The following is a description of a gene set: species: Homo sapiens Genes predicted to be targets of miRBase v22 microRNA hsa-miR-6882-5p in miRDB v6.0 with MirTarget v4 prediction scores > 80 (high confidence targets). from publication Chen Y, Wang X (PMID 31504780) Human Gene Set: MIR6882_5P, and this is the list of marker genes: RPS16, XRN1, LRRC17, NFIA, MAP7D2, HOOK3, TFDP1, ZNF451, GIMAP1, NUFIP2, GTF2A1, USP6NL, RASA2, CNOT6, CHIC1, ZNF594, ERI2, TM9SF2, CCDC32, STXBP5, UBE2E2, PLXNA1, PARD3, CASTOR1, DCAF12, ASB8, ANKIB1, CFAP97, MYO1B, PTP4A1, CXCL5, ILDR1, DCX, PARD6B, HGF, SKIL, MITF, SOCS5, GMNC, SPOPL, WEE1, AKIRIN1, LIPI, KIF13B, RCSD1, MYLIP, MINDY2, TENT2, CPEB3, TIMM23B, MEIS2, HYCC2, KDM5A, ARIH1, GOLGA1, SLMAP, MARF1, XPO1, SOWAHC, ZMYM1, SUDS3, AQP1, CCL13, IGSF10, CEMIP2, DIP2B, CAB39, SIPA1L1, COX7A2, NRIP1, ETV3, ZIC5, CADM3, CHMP5, MSL2, FN1, TBCEL, RYBP, ZNF736, IKZF2, PTPRB, TCHP, SEMA6D, MAPK1, LSM1, EIF4G2, AARD, ATRN, UBE2D3, DUSP6, TEK, DNAJC24, ARID4B, ISCU, PUM1, FAM120A, ZNHIT6, CDC42BPA, FHAD1, LURAP1L, TARDBP, UNC50, SLC25A24, LSM8, YTHDF1, MEF2C, ADAMTS3, DLST, EPB41L3, ZNF680, TRIB1, SLC36A3, LTN1, FH, MGAT4A, DBN1, NHLH2, ZBTB20, BRD1, CRTC1, DDX3X, MET, TANC1, MEMO1, DICER1, TM2D2, SERPINB11, CACHD1, PDE6D, HTR1B, ZBTB22 (NCBI Gene Id 9278), TIPARP, SIRT1 (NCBI Gene Id 23411), CHD6 (NCBI Gene Id 84181), RFTN2, ARPP19, NEDD1, KAT6A, ARFGEF3, CACNA1D, PHC3, ZNF521, FBXW11, SCAF8, MRPS5, SMAD6, CHGB, WDR76, MMP13, FAM107B, PMP22, EPB41L5, C3orf80, NFKBIA, KCNA3, SP4, ZNF22-AS1, BHLHE22, NXT2, LSM11, FOXC1, CGN, EFR3A, SCN2A (sodium voltage-gated channel alpha subunit 2), ATP1B1, REPS2, C15orf40, FLRT3, NECTIN1